The following is a description of a gene set: Any process that stops, prevents, or reduces the frequency, rate or extent of epithelial cell migration. studied in species Mus musculus Mouse Gene Set: GOBP_NEGATIVE_REGULATION_OF_EPITHELIAL_CELL_MIGRATION, and this is the list of marker genes: Pten (NCBI Gene Id 70161), Dusp10, Il4, Ptprg, Evl, Marveld3, Sema3a, Adipor1, Pfn2 (profilin 2), Ptprr (NCBI Gene Id 19279), Coro1c, Ptpn23, Dab2ip, Mcc, Macir (macrophage immunometabolism regulator), Tgfbr3, Cd63, Eppk1, Tacstd2